Given this list of marker genes Wdr18, Dnai4, Dnali1, Spag1, Dnaaf4, Dynlt2b, Dnaaf2, Ruvbl1, Dnai2, Dnaaf10, Stip1, Dnaaf11, Dnaaf5, Ruvbl2, Hsp90ab1, Zmynd10 (NCBI Gene Id 114602), Dnaaf8, Dnaaf3, here is a description of the gene set: An aggregation of axonemal dyneins, their specific assembly factors, and broadly-acting chaperones that is located in the cytoplasm. studied in species Mus musculus Mouse Gene Set: GOCC_DYNEIN_AXONEMAL_PARTICLE